Given this list of marker genes TIE1, ELF3, LIF, PSPH, MED1, PDGFB, THOC2, HORMAD1, FBLL1, KRT8, SLC5A7, ACVR1 (NCBI Gene Id 90), BCOR, WDTC1 (NCBI Gene Id 23038), FBXW8, POLB, FKBP10, FGFR1, TBL1XR1, E2F8, ENDOG, PITX2, IL10, KLF4, TERF2, CMTM3, DHX35, TGFBR1, MIB1, EGFR, KDM8, GLI3, ELF5, ESRRB, HOPX, CITED1, HSD17B2, SUPT6H, AXIN1, SH3PXD2A, RPA1, KPNA7, INPP5B, UBR3, CHST11, MSH2, TRIM28, SIN3A, RIC8A, MAF, GRHL2, CPT2, LLGL2, CIR1, BRCA2, SPINT2, IFITM5, CCDC24, MYB, DAD1, MDFI, C1orf43, EGFL8, TM4SF1, FOXD3, SEC24C, MGAT1, PLCD3, NSDHL, HAND1 (heart and neural crest derivatives expressed 1), NSUN2, RPL7L1, NLE1, ZFP36L1, TTLL4, AGBL4, TMED2, COPS3, EMG1, STIL, KIDINS220, LATS1, BNIP2, BIRC6, EMX1, CSF2, HEG1, CNOT2, AR, PSMC4, ZPR1, MAPK1, RRP7A, ZNF830, CNOT1, SMAD2, XRCC2, CHD7, NR5A2, PSMC3, CDX4, GSE1, ADAMTS3, NODAL, TTPA, PELO, SYF2, RNASEH2B, MYO18B, TBX3, MSX1, RRN3, E2F7, SPINT1, OCRL, CDX2 (caudal type homeobox 2), MBD3, GNA13, MXI1, MBNL1, MAN2A1, ZNF568, NR2F2, NASP, B9D1, HEY2, HSF1, TENT5C, SMARCB1, LIG4, ZFAND5, TFEB, TAB1, NBN, WDR19, EPN1, ELL, WNT7B, ST8SIA6 (ST8 alpha-N-acetyl-neuraminide alpha-2,8-sialyltransferase 6), PADI6, NOTCH1, HCFC1, FOSL1, CHEK1, MYH9, ZMIZ1, NDEL1, MYH10, SEC24D, PHLDA2, HES1, ITGB1, WDR74, PTH1R, TTLL1, POLG2, CTCF, CCNB1IP1, VASH1 (vasohibin 1), CHD8, KAT2A, UBTFL1, SBDS, NOG, DIAPH3, VASH2, STK4, BRK1, PPP4R4, SOX10, ACVR1B, YBX3, GINS4, RTF1, YTHDC1, SUV39H1, SOX15, APBA3, DNAAF2, BMP7, DSC3, NPAT, KDM4C, TAF8, GABPA, OVOL2, TGFBR2, RUNDC1, SMAD4, ASF1B, MAFG, MAFF, AMOT, PPP1CC, SMO, TCTN1, VPS54, SOX17, MFNG, CCNB2, ZNF335, TP53, FOXC1, PRDM14, CUL3, BTF3, PNLDC1, CCN1, GINS1, FGFR2, GRB2, ST14, C6, CITED2, PTPN18, AKT1, FKRP, GATA6 (NCBI Gene Id 2627), RDH10, SMAD3, BMP2, OTUD7B, BCL2L11, BYSL, TAF10, IWS1, HS3ST6, HIF1A, CAMSAP3 (NCBI Gene Id 57662), PCGF2, EIF2S2, IGF1, TFAP2C, AKAP3, FURIN, TMEM100, CERT1, COPS2, HNF1B (HNF1 homeobox B), SLC35E2B, TMEM231, ADM, MATR3, NOS3, RTCB, NOTCH2, ZFP14, MT-ND4 (NCBI Gene Id 4538), CCM2, MFN2, TRAF6, FUT8, RBBP6, FOXF1, ANGPT1, GATA1, RRM2, WNT2, ADAM10, MOSMO, TEAD4, CCDC62, MAP2K1, ADCY9, UPF3A, NSRP1 (nuclear speckle splicing regulatory protein 1), RTN4, PRDM1, RXRB, PHF6, GNA12, GPI, APBA2, MYH6, PTCH1, CAPN2, SMIM14, YAP1, SF3B6, RPL13, APBA1, PLPP4, ASCL2, CTNNB1, TGFB3, PKD2 (polycystin 2, transient receptor potential cation channel), HEY1, ARNT, HINFP, EPB41L5, BPTF, SCO2, PCDHA10, SENP2, GCM1, IGF2, ETNK2 (NCBI Gene Id 55224), RBM46, EPAS1, ZP3, ERCC2, MAFB, SPECC1, EDNRA, FLCN, NECAB1, PTPRR, KLF2, CCNB1, APOB, TWIST1, SALL4 (NCBI Gene Id 57167), ATF2 (activating transcription factor 2), BCL2L1, PEMT, PLOD3, UBE2B, FZD5, HDAC3, SKIL (NCBI Gene Id 6498), ARMC5, SOCS3, MED21, ADA, SOX18, COL3A1 (collagen type III alpha 1 chain), UNK, VEGFA, ACVR1C, GATA2, DNAJB6, INPP5K, ETV2, IHH, EOMES, RBBP8, CMIP, SLC34A2, SLC25A20, GATA3, LATS2, PLG, SPIC, CEBPA, CNOT3, EDN1, WNT3A, RCN1, CUL4A, GJB5 (NCBI Gene Id 2709), PKD1, STK3, WNT9B, RPGRIP1L, JUNB, SLC25A34, PRMT1, PDGFRA, SNAI1 (snail family transcriptional repressor 1), NEK2, ALKBH1, POU5F1, CDKN1C (NCBI Gene Id 702), NCKAP1, NCOA1, CTR9, GRN, GGNBP2, DBN1, GDF3 (NCBI Gene Id 9573), SOX8, SSR2, PCDH12, CEBPB, NDUFA2, RAD51B, CHTOP, NCAPG2, HAND2, SLC39A1, LEF1 (lymphoid enhancer binding factor 1), SRF, STMN3, BMI1, HS6ST1, NXN, ACTL6A, BMPR1A, BMP5, INTS1, BAP1, SRSF1, NPM2, UPB1, KIFBP (NCBI Gene Id 96724), PLK4, JAG2, GDF1, KEAP1, SMG9, PRPF19, PALB2, ANKS6, RBPJ, SP3, SLC39A3, ACVRL1, KRT19, FLVCR1, CDKN1A (cyclin dependent kinase inhibitor 1A), RSPO3, SLC30A1, ARNT2, MYBPHL, CELF4, ZBED6, N4BP2L2, ARHGDIG, TET1, NMT1, XAB2, CASP8, HM13, C2CD3, LPAR6, MYO1E, ZFPM2, EGLN1, YBX1, here is a description of the gene set: The process whose specific outcome is the progression of the embryo in the uterus over time, from formation of the zygote in the oviduct, to birth. An example of this process is found in Mus musculus. studied in species Homo sapiens Human Gene Set: GOBP_IN_UTERO_EMBRYONIC_DEVELOPMENT